Given this list of marker genes DCAF12, HOMER1, NFIL3, SLC11A2, VRK3, CD1D, ASS1, DCUN1D3, CAMP, NKX2-2, SOS2, PRELID2, PLD1, FAM162A, E2F1, TRPS1, PPP1CB, MCUB, GPD2, CAPNS1 (calpain small subunit 1), THOC6, DR1, TMBIM4, CGRRF1, ACSL1, TIFAB, ACY1, PRDX5, GAB1, CDC42BPG, TRPM2, MOB3B, TEX29, STARD5, PKM, GFPT1, DOCK7, MMP14, FKBP2, RLF, ABHD11, NFKBID, GAS2, HCCS, ZNF597, LRRC8D, PON3, LDHA, ARHGAP24 (NCBI Gene Id 83478), IPMK, NSDHL, PPP1R21, RAB10, HMBS, ARHGEF37, BTD, FDFT1, MET, N4BP1, CD80, SIGLEC7 (sialic acid binding Ig like lectin 7), MFSD14B, FAS, TMEM123, CEMIP2, ENO1, IGSF1, ATP2C1, NDUFA11, AK4, MALT1, NFKBIZ, FOXN2, PSTPIP2, LAYN, GZF1, TMCC1 (transmembrane and coiled-coil domain family 1), CCND3, FABP7 (fatty acid binding protein 7), RNF19A (ring finger protein 19A, RBR E3 ubiquitin protein ligase), C19orf12, EGLN3, PLSCR1, P2RY13, VHL, CDKN2D, PI4K2B, BATF, RNF149, PARP3, MAFF, BSDC1, ACSL3, LAMTOR4, H3C14, NUFIP1, ECI2, SLC39A4, KDM3A, AOAH, CDV3, JUNB, MRPL33, PPP3R1, GK (glycerol kinase), PCID2, ERP44, DNAJC10, TM7SF2 (transmembrane 7 superfamily member 2), NFE2L2, UBXN1, MIF, GINM1, PLEKHG1, CEP57, PLA2G4A, S100A10, MARCKSL1, GSR, PGK1, RMC1, DHRS1, GPAA1, TNFAIP8, SLC29A1 (NCBI Gene Id 220811), PIK3R6, STARD4, UBAC2, SPHK1, YPEL2, C1R, TGM2, MS4A8 (NCBI Gene Id 83661), SLC37A4, PTK2, SH2B2, IQCC (NCBI Gene Id 55721), TMEM37, MKI67, DLAT, SNX6, CD302, RAB12, ZBTB1, SLC2A6, SLC16A1, PAFAH1B2, EIF6, PHYHD1, TIMM8B, CUL4A, TNFSF9, AACS, MLX, ZBTB18, EPM2AIP1, NFE2 (nuclear factor, erythroid 2), LTB4R, SC5D, RAB3D, SAMSN1, LARS2, CNPY4, TNFRSF14, MSL1, DNMT3L, STARD7, CCNO, CEPT1, ZNF292, C5orf15, FLOT1, CSF2RB, DNPEP, AK2, IGSF6, RIPK3, HAL, IFT57, NUBP1, LAPTM4A, NTAQ1, SLC25A30 (solute carrier family 25 member 30), MRPL45, ABCC5, ABCA1, FXYD2, PLBD1, USPL1, SQLE (NCBI Gene Id 6713), CDADC1, ECHDC1, MAGT1, IFITM2, AIFM2, KCTD9, APP, TMEM167B, PYGL, TMEM106B, here is a description of the gene set: Genes up-regulated in macrophages: wildtype versus PPARG knockout. Human Gene Set: GSE24292_WT_VS_PPARG_KO_MACROPHAGE_UP from publication Roszer T, Menéndez-Gutiérrez MP, Lefterova MI, Alameda D, Núñez V, Lazar MA, Fischer T, Ricote M (PMID 21135166) species: Homo sapiens PPARg is a nuclear receptor that plays an important role in lipid metabolism, homeostasis and immunity. Microarray analysis of gene expression was performed in macrophages from WT and PPARg KO mice. Differentially expressed genes were selected for further analysis.